Given this list of marker genes Spred2, Kl, Fgf20, Uba52rt, Ptbp1, Polr2f, Fgf4, Mapk1, Tgfbr3, Spry2, Fgfr1, Pik3r1, Fgf15, Ptpn11, Fgf6, Polr2k, Fgf18, Ppp2ca, Mapk3, Mknk1, Polr2d (polymerase (RNA) II (DNA directed) polypeptide D), Frs2, Cbl, Fgf22, Hnrnpa1, Uba52, Grb2, Plcg1, Flrt1, Ncbp2, Fgf3, Polr2e, Braf, Polr2b, Flrt3, Polr2c, Hras, Pik3ca, Fgf7, Fgf17, Kras, Polr2g, Ppp2r1a, Fgfbp1, Fgf9, Rps27a, Ncbp1, Fgf5, Fgfr3, Polr2i, Gab1, Sos1, Fgf8 (NCBI Gene Id 14179), Gipc1, Gtf2f1, Polr2h, Frs3, Flrt2, Spred1, Galnt3 (polypeptide N-acetylgalactosaminyltransferase 3), Shc1, Src, Gtf2f2 (NCBI Gene Id 68705), Ubb, Polr2a, Fgfbp3, Fgf2, Fgf10, Ppp2cb, Polr2l, Fgf16, Fgfr4, Ubc, Fgf1, Klb, Fgfrl1, Fgf23, here is a description of the gene set: Signaling by FGFR Mouse Gene Set: REACTOME_SIGNALING_BY_FGFR species: Mus musculus